The following is a description of a gene set: studied in species Homo sapiens Human Gene Set: GSE3982_CENT_MEMORY_CD4_TCELL_VS_TH1_UP In the present study we used Affymetrix oligonucleotide microarrays to produce gene transcription profiles for the major leukocyte types in humans. This comprehensive dataset enabled us to not only establish which genes were expressed in each leukocyte type, but also which genes were expressed in each subset after activation. The used of a comprehensive dataset of gene profiles from all the major human leukocyte subsets enabled a novel and powerful means for identification of genes associated with single leukocyte subsets, or different immune paradigms. Genes up-regulated in comparison of central memory CD4 T cells versus Th1 cells. from publication Jeffrey KL, Brummer T, Rolph MS, Liu SM, Callejas NA, Grumont RJ, Gillieron C, Mackay F, Grey S, Camps M, Rommel C, Gerondakis SD, Mackay CR (PMID 16474395), and this is the list of marker genes: DCLK1, ZNF529, FOXL1, GSE1, RPL39, IL18, ZCWPW1, ZNF337, ABCD4, SLC46A3, PKD1P6, HAS2, ATXN7L3B, FKBP10, EXOC1, CUL4A, DIDO1, C1orf115, SSPN, ZNF117 (zinc finger protein 117), RHO, PTCD2, CD44, KRT36, LONP2, SULT1B1, HLA-F, SMIM7, JMJD1C, ZBTB25, RORC, EFCAB14, MKKS, RPS17P5, ITIH4, AMHR2, CLSTN1, SSTR1, GATA3, BACH2, LMBR1L, CSPG4, LRRC1, MTRF1L, ZFYVE9, MMP10, LZTFL1 (NCBI Gene Id 54585), UBASH3A, LY75, DMTF1, MKRN1, NACA, PRKY, EEF2, AQP3, CD84, CLDN16, OSBPL8, CD300A, CLOCK, FTO, RADX, CCNT2, MED25, POPDC2, OCEL1, ZNF202, S100A8, F8, POGZ, CPN1, RAPGEF6, PRPF3, LUC7L3, IFNAR2, ANXA1, SP3P, AHCYL2, TDRKH, ZNF266, BTN2A1, NCK2, PSORS1C1, PCF11, PRL, RAB11FIP4, FRAT1, TTC17, ECE1 (NCBI Gene Id 1889), GOLGA8A, C1orf56, CIRBP, PCDH8, RPLP2, CHMP7 (charged multivesicular body protein 7), PDE3B, PLSCR3, GCNT4, KCNN3, MUC7, ZFP36L2, MAP3K5, DGCR8, BOK, HLA-C, H2AC25, TSPAN6, USP25, STUB1, SCML1, DENND1B, PIK3IP1, GABRA3, PI4KA, EMSY, SPATA7, TENM1, SLC35E2B, KATNIP, SMURF1, VTCN1, MVB12B, TREH, MDFIC, FGF9, TRIM44 (NCBI Gene Id 54765), SNX29, THRB, SIRPG, TEX28, HRC, ARHGAP26, RBP3, BIN1, GPR6 (G protein-coupled receptor 6), GPRASP1, NOX3, MARCHF8, GFOD3P, AMIGO2, ZNF432, PATZ1, TP53TG1, DUOX2, GLRA3, FGF22, MEGF6, KBTBD2, MIA2, CYB561, IMPACT, HBP1, AMBN, ATP2C2, DPY19L2P2, CSGALNACT1, CSRP3, RABL3, FAM13B, TCF7, NR3C1, CUZD1, CAPRIN2, STAG3L4, RIC3, CABP5, COX7A1, LRRC37BP1, ZBTB7A, CTSS, RUFY1, BBS1, CARS2, HLA-DPB1, TXNRD3, NHLRC2, IFT70A, TUBG2, FCN3, PLAC8, PIK3R1, CPQ, ZNF14, DNAH2, ARHGAP15, DENND5A, PCNX2, CAPN3, KIR2DL2, PHF1, TRAPPC2, TRANK1, MAGEA4, TRIM13, HCG4B, VAMP1, ZBTB18, EPHA1